Given this list of marker genes Cdh5, Lyl1, Mmp2, Reck, S1pr1, Ankrd17, Ddit3, here is a description of the gene set: species: Mus musculus A developmental process, independent of morphogenetic (shape) change, that is required for a blood vessel to attain its fully functional state. Mouse Gene Set: GOBP_BLOOD_VESSEL_MATURATION